Given this list of marker genes KLRK1, KLHDC10, MIR1-2, SPR, GCNT7, ZCWPW2, NUDT1, NUDT19 (nudix hydrolase 19), GREM2, TSLP, RIC8B, CXCR2, HTR2A, ABCA4, FRZB, PIK3R6, NEFH, TMC3, KLRC2, IPO9, HOXB2, MED11, ATP6V1C2, HACD1, TTC12, UBE2V1, AQP11, ZDHHC5, TBL3, SERPINB11, SLC2A1, NUTF2, STAG3, RFX5, IGSF9, FAP, DIPK1C, BCL2L1, HSD17B11, IQCF1, OSM, MIR27A, NSG1, PKM, PLEKHG1, LY6G5B, GPR83, CHSY1, DHDDS, PSME2, RANBP3L, CXCL9, DIS3L, BEX4 (brain expressed X-linked 4), SLC35F3, PGAM1, GARIN1A, TLR3, BOP1, MAP3K12, OPRL1, GAPDH, IL10RA, SIX4, PWP2 (NCBI Gene Id 5822), PAXIP1, CP, RANBP1, REXO2, HMGXB3, NTS, JOSD2, B4GALT5, DGKG, GART, IRF8, QSOX2, IL21R, NECAB1, EFTUD2, UBE2F, SYNPO, PMP2, SLITRK1, DGKB, ANTXRL, UBA2, KIF1C, RAPGEF5, SULF2, KCNA4, TUBB6, MBL2, PRSS33, EMILIN2, GUSB, CELF5, LSS, PNMA5, SNX9, IGSF1, KCNIP4, DDN, XRRA1, FERMT1, PTN, F2RL2, HOXC13, CCDC116, FAM120A, CDK14, TOMM40, RUNX1T1, JAGN1, ICAM1, COQ7, POFUT1, PSMC4, ATXN7L3, TXNL4B, STX4, SLAMF9, DYNLL1, UXS1, MRPS25, GLRB, MIR450B, TRIM40, CCN6, THSD1, KIF27, GUCY1A2, TXNRD1, POU1F1, MLST8, VAC14, IL2RB, GRWD1, EN2, ERRFI1, here is a description of the gene set: Genes down-regulated in skin from INFG knockout mice after injection of: control versus Trypanosoma cruzi (strain Y). Human Gene Set: GSE13522_CTRL_VS_T_CRUZI_Y_STRAIN_INF_SKIN_IFNG_KO_DN studied in species Homo sapiens from publication Chessler AD, Unnikrishnan M, Bei AK, Daily JP, Burleigh BA (PMID 19201883) To investigate the early host response triggered by three different strains of Trypanosoma cruzi at a local infection site, changes in host gene expression were monitored in a murine intradermal infection model using Affymetrix oligonucleotide arrays. Robust induction of IFN-stimulated genes (ISGs) was observed in excised skin 24 hours post-infection where the level of ISG induction was parasite strain-dependent with the least virulent strain triggering a muted IFN response. Infection of mice immunodepleted of IFNγ-producing cells or infection of IFNγ-deficient mice had minimal impact on the IFN response generated in T. cruzi infected mice. In contrast, infection of mice lacking the type I IFN receptor demonstrated that type I IFNs are largely responsible for the IFN response generated at the site of infection. These data highlight type I IFNs as important components of the innate immune response to T. cruzi the site of inoculation and their role in shaping the early transcriptional response to this pathogen. We used microarrays to detail the local host transcriptional response to intradermal T. cruzi infection in WT mice and mice depleted of NK cells, or deficient in IFN-gamma or type I IFN responses. Additionally we compared the local host-transcriptional response generated to infection with 3 different strains of Trypanosoma cruzi (Y, Brazil, and G).